Given this list of marker genes ITPRID2, ENDOV, ITGAV, RORA (RAR related orphan receptor A), PLOD1, STT3A, CCNT1, ZNF35, SPHKAP, SYNPO2, ZZZ3, ZKSCAN2, PLCXD2, CADM1, OOSP2, IDS, TMEM121B, GORASP2, TNFAIP8L3, PPM1A, LCOR, SDK2, MAFB, POGLUT1, VPS53, NAV2, FBXL5, ZNF322, KCNB1, here is a description of the gene set: Genes predicted to be targets of miRBase v22 microRNA hsa-miR-6862-3p in miRDB v6.0 with MirTarget v4 prediction scores > 80 (high confidence targets). species: Homo sapiens Human Gene Set: MIR6862_3P from publication Chen Y, Wang X (PMID 31504780)